Given this list of marker genes Ip6k2, Ip6k1, Ip6k3, Ppip5k2, Ppip5k1, here is a description of the gene set: Mouse Gene Set: GOMF_INOSITOL_HEXAKISPHOSPHATE_5_KINASE_ACTIVITY Catalysis of the reaction: 1D-myo-inositol hexakisphosphate + ATP = 5-diphospho-1D-myo-inositol 1,2,3,4,6-pentakisphosphate + ADP. species: Mus musculus